Given this list of marker genes CCL5, CXCL9, TLR3 (toll like receptor 3), TLR7 (toll like receptor 7), CXCL8, here is a description of the gene set: Human Gene Set: GIAROLA_SILVA_BLOOD_PANDEMRIX_AGE_21_51YO_3DY_UP from publication Giarola-Silva S, Coelho-Dos-Reis JGA, Mourão MM, Campi-Azevedo AC, Nakagaki Silva EE, Luiza-Silva M, Martins MA, Silveira-Cassette ACO, Batista MA, Peruhype-Magalhães V, Antonelli LRDV, Leite Ribeiro JG, Elói-Santos SM, Machado AV, Teixeira-Carvalho A, Martins-Filho OA, Araújo MSS (PMID 28549970) The study aimed at identifying biomarkers of immune response elicited by non-adjuvanted-(NAV) and adjuvanted-(AV) H1N1(pdm09) vaccines. The results showed that despite both vaccines elicited similar levels of anti-H1N1 antibodies at day30 after vaccination, higher reactivity was observed in AV at day180. While AV induced early changes in cell-surface molecules on monocytes, CD4<sup>+</sup>, CD8<sup>+</sup> T-cells and B-cells, NAV triggered minor changes, starting later on at day3. Furthermore, AV induced a late and persistent increase in TLR gene expression after day3, except for tlr4, while NAV displayed earlier but transient tlr3/4/7/9 up-regulation. Contrasting with NAV, prominent chemokine gene expression (cxcl8,cxcl9,ccl5) and a broad spectrum up-regulation of plasmatic biomarkers (CXCL8,IL-6,IL-1beta,IL-12,IL-10) was evident in AV, which showed a major involvement of TNF and IL-10. Similarly, AV induced a robust IL-10-modulated proinflammatory storm, with early and persistent involvement of TNF-alpha/IL-12/IFN-gamma axis derived from NK-cells, CD4<sup>+</sup> and CD8<sup>+</sup> T-cells along with promiscuous production of IL-4/IL-5/IL-13. Conversely, NAV promotes a concise and restricted intracytoplasmic chemokine/cytokine response, essentially mediated by TNF-alpha and IL-4, with late IL-10 production by CD8<sup>+</sup> T-cells. Systems biology approach underscored that AV guided the formation of an imbricate network characterized by a progressive increase in the number of neighborhood connections amongst innate and adaptive immunity. In AV, the early cross-talk between innate and adaptive immunity, followed by the triad NK/CD4<sup>+</sup>/CD8<sup>+</sup> T-cells at day3, sponsored a later/robust biomarker network. These findings indicate the relevance of adjuvanted vaccination to orchestrate broad, balanced and multifactorial cellular immune events that lead ultimately to a stronger H1N1 humoral immunity. species: Homo sapiens Genes up-regulated in blood 3d vs 0d in adults (21-51) after exposure to Pandemrix, time point 3D, administered i.m.